The following is a description of a gene set: Human Gene Set: GOCC_DENDRITE_TERMINUS species: Homo sapiens A structure at the distal end of a dendrite adapted to carry out a specific function, e.g. dendriole., and this is the list of marker genes: GRM1, SLC32A1, IFT52, CDKL5, CALB2 (calbindin 2), MAP2, IFT57, PTCH1, HSP90AB1, MAPK8IP1, TAOK2, RGS7, IFT20, COBL (NCBI Gene Id 23242), HSP90AA1